Given this list of marker genes Psph, Serinc4, Serinc1, Psat1, Sds, Serinc2, Serinc5, Sdsl, Serinc3, Phgdh, Srr, here is a description of the gene set: species: Mus musculus Serine metabolism Mouse Gene Set: REACTOME_SERINE_METABOLISM